Given this list of marker genes MRPS34, PIGW, BCORL1, VPS33A, CLCN4, PTCH2, BAZ1B, MAP3K7, TMEM53, SNX14, AGA, KRAS, TBC1D7, VPS37D, NANS, EXTL3, GNE, ABCC9, TBL2, HRAS, SOST, PIGS, PPP3CA, AIP, DPF2, SUMF1, NAGLU (NCBI Gene Id 4669), FKBP6, DNAJC30, PDE4D, PIGV, AP4M1, TARS1, GJA1, XYLT1, COQ4, HPGD, PGAP3, ARX, RFC2, PIGA, H4C5, VPS11, RIN2, FBXO31, SMARCA4, RPS6KA3, CCDC47, CARS1, GNPTG, SLC35C1, NCF1, PPP1R21, TNPO2, INTS11, BRAF, AP3B1, CNTNAP2, DYM, NMNAT1, MAGEL2, KCNH1, GPR101, NAGA, CRELD1, ACTG1, FOXE1, AP4E1, AIFM1, ZNF148, MMP14, PIGL, KIF15, AIMP1, GLA, GPC3, ZNF699, HMBS, DLG5, CLIP2, RAI1, CTCF, AHDC1, L1CAM, ATRX, ARID2, KDM6B, EIF4H, SMARCE1, PGAP2, SP7, DENND5A, PLAA, GLB1, NOTCH2, ARSB, SETBP1, SLCO2A1, KAT6B, IQSEC2, KCNQ1OT1, ZSWIM6, AFF4, SUFU, RNF113A, SGSH, TMEM270, SOX11, AP1S2, RBMX, LYSET, PIGB, GTF2I, KCNN3, FTO, PIGY, ARSK, DEAF1, SH3PXD2B, GALNS, HEXB, MAB21L1, PIGO, PAX8, ALG13, GTF2H5, NEU1 (NCBI Gene Id 4758), MBD5, PTCH1, MCTP2, FAR1, TBCK, SPEN, GTF2IRD1, MMP2, NSD1, FBXO11, INSR, SMARCC2, MPLKIP, TMEM147, FMR1, ELN, CEP120, MPL, EHMT1, NKX2-5, PUS3 (pseudouridine synthase 3), MCOLN1, GUSB, KCNJ8, ARID1A, P4HTM, NAA10 (N-alpha-acetyltransferase 10, NatA catalytic subunit), IDS, TBC1D2B, ACBD6, BRCA1, AP4B1 (NCBI Gene Id 10717), ARID1B, SMARCD1, PIGN, ERCC3, CNP, METTL27, MAPK1, BAP1, IDUA, MAP2K1, FLNA, SPTBN1, GNPTAB, SLC17A5, LIMK1, HDAC4, STAT3, TCF4, THSD1 (thrombospondin type 1 domain containing 1), HNRNPK, SLC35A2, THPO, ALG14, MAN2B1, GNS, TFE3, ABCA5, ADNP, DNMT3A, PIGF, SLC26A4, SMARCB1, ACER3, SPRED2, GTF2IRD2, AARS1, ZFX, SOX4, CDKN1C, CHD4 (NCBI Gene Id 1108), BUD23, KCNQ1, PACS2, ACTB, WDR81, GPC4, COL2A1, FLII, NRCAM, CTSA, BSCL2, OTUD5, CLIC2, RAB33B, TBC1D24, EXT2, MED12, AP4S1, HGSNAT, NF1 (NCBI Gene Id 646021), CUL4B, ANTXR2, NKX2-1, PIGQ, GTF2E2, ERCC2, MAP2K2, ATP6V1B2, STX1A, MEN1, FUCA1, MYSM1, PIK3C2A, APC2, SVBP (small vasohibin binding protein), LAMTOR2, WAC, HS2ST1, IGF2, FHL1, PHF6, TSHR, LTBP1, WDR26, KLHL15, here is a description of the gene set: Human Gene Set: HP_COARSE_FACIAL_FEATURES Coarse facial features Absence of fine and sharp appearance of brows, nose, lips, mouth, and chin, usually because of rounded and heavy features or thickened skin with or without thickening of subcutaneous and bony tissues. species: Homo sapiens